Given this list of marker genes SEMA4F, PRPF38A, STX5, GNS, SLC25A17, TXNDC16, VPS29, C9orf72, PDCL3, MAT2A, OAT, BTK, TMX2, NPHP1, SLC35E4, ARPC3, HCN1, UBAC1, HSPA4, GORASP2, COL18A1, CASP6, BOLA2, MRPL18, SPART (NCBI Gene Id 23111), GTF2H1, ADAM19, GYS1, ALDH9A1, ADK, RPN2, CXCL9, RNF141, STBD1, AKR1A1, USP24, RPL37A (NCBI Gene Id 6168), CD8A, XCR1, CSDE1, CXCL10, NKIRAS2, POLR2J, ENTPD2, AGPAT3, CSTB, RPS27L, LGALS3, TUBB6, STX12, CENPV, PLEKHH1, JUP, KRTAP19-5, SELENOT, GCSAM, GTF3C4, NUCB1, ATP6V1A, GDF3, IRF8, IST1, NCOA4, MDN1, PPFIBP2, LDAF1, RNF4, NDUFA12, MRC1, CRHR1, VWF, LIMD1, PRM3, ATG13, RIOK3, PDIA5, LSR, FAM91A1, PSMA5 (NCBI Gene Id 5686), AAMDC, CD9, SQSTM1, ASAH1, IQGAP1, SRPK3, CTBP2, REEP5, CKAP4, CD70, POMP, ADAM8, GDF15, PLPP1, ENTPD1, SERPINB9, ODC1, RASA3, PLSCR1, ACTN2, RPS6KC1, UCHL5, CD5L, CMTM7, GRK5, ECE1, NEDD8, TTC1, CD1D, SLC12A7, PROCR, FLT1, HDDC2, CYFIP2, PBX1, MFSD14A, FGF5, KRTCAP2, PPT2, FKBP1A, PTGER2, ARID3B, ZNF703, MFSD5, CYB5R1, KIF3C, HFE, DPP7, SEMA4A, APC, P4HB, ETF1, SOD1, DNAJC3, ITM2C, PTPRB, SYNRG, PTPRA, EPHA3, OR4C3, NUDT9, MERTK, PHC2, B3GALNT1, CD8B, AIF1, GNG2, VCP, GSR (NCBI Gene Id 2936, glutathione-disulfide reductase), ATP1B3, SMIM11, CARS1, TXNDC17, NEK6, VPS37C, RRAGC, PTGIS (prostaglandin I2 synthase), RCN3, UBE2N, GLCE, BRIX1, NDUFA3, TYMP, SEC61A1 (NCBI Gene Id 83289), STX3, DNAAF10, NDST2, FNDC7, CSF2RB, TENT5C, TUBB2A (tubulin beta 2A class IIa), MICOS10 (mitochondrial contact site and cristae organizing system subunit 10), TAP1, AMZ2, ACYP1, SLC11A1, MYCL, POLR2H, GLRX, DNAJC8, GUCA1A, LAP3, RGS10, PDE1B, IL11RA, RSU1, MICOS13, METAP1, UNC119B, ANAPC13, SSR3, SLC25A1, IL18, COL1A1, NCBP2, PPEF2, KCNMB1, SPOP, MC1R, OLFM1, OXCT1, here is a description of the gene set: studied in species Homo sapiens The functional relationships and properties of different sub-types of dendritic cells (DC) remain largely undefined. We used a global gene profiling approach to determine gene expression patterns among murine splenic CD11c high DC subsets in an effort to better characterise these cells. Genes up-regulated in comparison of CD8 dendritic cells (DC) versus CD4- CD8- DCs. Human Gene Set: GSE339_CD8POS_VS_CD4CD8DN_DC_UP from publication Edwards AD, Chaussabel D, Tomlinson S, Schulz O, Sher A, Reis e Sousa C (PMID 12816982)